Given this list of marker genes GSDMD, UQCC3, PITPNC1, PLEKHN1, UCP1, IRGM, GSDME, SPATA18, GSDMB, ATP8B1, STOML2, PLTP, MME, PITPNA, OPA1, RPE65, ANXA13, NME4, here is a description of the gene set: Human Gene Set: GOMF_PHOSPHATIDYLGLYCEROL_BINDING Binding to phosphatidylglycerol. species: Homo sapiens